Given this list of marker genes OVGP1, SNRPF, MANF, GFI1, ARHGAP29, KCNH2, GUCY2F, TRPC6, LAMB2, CRH, NR3C2, NOVA1, ARPC2, COL3A1, HOXD10, NECAB3, CEBPA-DT, HOXB3, TTYH1, HAPLN1, CHP2, PTPRJ, FOXN3, RXFP2, EMX2, HOXB9, RAB3C, TCL1A, MON1A, SCUBE3, HOXC6, LRRTM1, NREP, ACVR2A, ARHGAP33, DOCK4, MRPS18B, TGM5, HNRNPA3, AXIN2, EN1, GNAO1, SMAP2, CDIN1 (NCBI Gene Id 84529), KIF5A, HMGN2, PCSK5, ZBTB33, GPR151, MPP4, IGF1, SSPN, RARB, PAX2, BZW2, RTL9, CTBP2, RBPMS, FAM180A, LINC00173, IL1RAPL1, SLITRK5, ELAVL2, FOXP2 (forkhead box P2), FBXL19-AS1, OSBPL7 (oxysterol binding protein like 7), MED27, B3GLCT, GLRA1, BCL9L, PDZRN4, CRY1, ABLIM3 (actin binding LIM protein family member 3), CELF4, MAST2, CSF2, ZNF277, MARCKS, TINAG, SLC5A2, NPAS3 (NCBI Gene Id 64067), DMD, SIAH3, PKP4, SP6, CNTLN, FRY, UCN2, PLEC (NCBI Gene Id 5339), MYH13, ATP2A3, GRIK3, PHF3, ETV6, KCNK18, IKZF2, MEOX2, MCTP1, PI4KA, RFX4, KRTAP19-5, GDF7, ENO3, JADE1, ARHGAP8, ZBTB2, SOX1, CA10 (carbonic anhydrase 10), SOX14, NCKAP5, CPB1, MIR600HG, SMG5, PPP1R14D, MXI1, ZIC2, TSSK1B, JAKMIP2, RAB33A, TAFA1, APOBEC2, C1orf87, COL19A1, TMEM179 (transmembrane protein 179), HOXB2, BRINP3, STMN2, KIF1B, AGTR2 (NCBI Gene Id 186), SOAT2, IL3, LBX2-AS1, ERG, DLC1, ARHGEF38, SLC43A3, PPP1R2C, SUCNR1, WWC2, CPLX2, OSTC, MYOD1, ABLIM2, CALB1, MYOG, CAMK2D, SAMD11, BNC2, UBE2W, NKD1, NUDT2, ADD3, RBMXL2, NAP1L5, EYA1, MAP4K2, PPP2R2B, PWWP2B, PDZD2, PRKG2, NFIX, CALD1, RGS8, NEUROD6, RNF43, H3-3B, SMARCA2, PI15, CPNE1, EIF4E, ANGPTL3, CDH9, HOXA1, KCNA3 (NCBI Gene Id 3738), PALMD, LRP8, TBXAS1, ATP2A2, ZIC1, CSRNP1, ARF4, APRG1, SCGB3A2, TAC1, OMG, DACH1 (NCBI Gene Id 1602), FAM135B, HOXD3, SP4, MN1, ANK2 (NCBI Gene Id 4028), F9, CLC, SLC12A1, WNT4, GOLGA1, CARMIL1, SLC2A13, PRICKLE1 (prickle planar cell polarity protein 1), SPRED1, PPP1R10, HNMT, MAGI3, OTOP3, DYRK1A, SOX2, SPAG6 (sperm associated antigen 6), NXPH4, DKK4, DSG3, GPX1, SYNRG, GC, FOLR2, TENM3-AS1, MSS51, IGF2BP3, PBXIP1, SORBS1, IRX3, ABCB5, CEBPA, TAF15 (NCBI Gene Id 8148), PRPF38B, HCRTR2, S100A16, ZNF512, G6PC1, CERS6, RAB43, PNOC, SSTR1, GRK5, LUC7L, SHISA6, IL23A, FGF5, NPTX2, COLQ, PITPNC1, RBM39, MBNL2, RNF212, RASL11B, GARIN1B, C8orf17, PLCXD2, CHM, MLIP, CA4, PRKAG1, CFL2, ELMO1, DAAM1, FBXL19, PJA2, FNDC3A, DHX58, KCTD8, MITF, STARD13, HNF1A, ZCCHC24, UBE4B, AQP5, TMEM79, NOB1, RBFOX1, HOXA2, AKIRIN2, LMO4, RASGEF1B, RTKN2, WBP2NL, SAT1, EVX1, NEB, HOXC10, SMPX, SLC16A10, C12orf50, CCDC148, ANKS1B, KCTD12, ZBTB18, POU3F4, WNT6, PKD2L2, TMEM184B, VAT1, ANKMY2 (ankyrin repeat and MYND domain containing 2), GPC3, CPEB4, EHF, CSF3, TMIE (transmembrane inner ear), MOXD1, FLRT3, POLR3D, GRIA3, CTNNA3, ACKR3, TMBIM1, ZNRF1, EGR3, APP, ST7, SEMA3A, TCF7L2, SORT1, USP51, SEC14L2, GRIN2B, HOXA7, CRCT1, STAT5B, PRDM13, BHLHE22, HOXB7, NALCN, FAM91A1, POU6F2 (POU class 6 homeobox 2), CREB5, NOL4L, NANOS1, DCX, AGAP4, TJP2, CCDC171, IL21 (NCBI Gene Id 59067), ROBO3, HOXA10, PHF20L1, ORAI3, C1QTNF3, BMPR1B, GARIN4, STAT3, QKI, PRL, AFF2, ZBTB37, ADAMTS6, KCNQ4, THBS1, PTF1A, SLITRK2, MAP2K5, LINC00671, COL4A6, RPRD2, SLC13A1, TLE4, F12, DNAJB4, BEND6, DLG2, KRT77, KRTAP11-1, CCDC80, MIR9-1HG, KCNIP2 (NCBI Gene Id 30819), WWP2, NDP, MBL2, ID2, GABRB3, DCSTAMP, NSD1, CCNYL1, YIPF7, SLC38A3 (NCBI Gene Id 10991), BEND4, SYT1, PLEKHH3, E2F1, DOCK7 (NCBI Gene Id 85440), SUPT4H1, PTCHD1, TRERF1, SUMO4, HOXB4, here is a description of the gene set: Comprehensive identification of all functional elements encoded in the human genome is a fundamental need in biomedical research. Here, we present a comparative analysis of the human, mouse, rat and dog genomes to create a systematic catalogue of common regulatory motifs in promoters and 3' untranslated regions (3' UTRs). The promoter analysis yields 174 candidate motifs, including most previously known transcription-factor binding sites and 105 new motifs. The 3'-UTR analysis yields 106 motifs likely to be involved in post-transcriptional regulation. Nearly one-half are associated with microRNAs (miRNAs), leading to the discovery of many new miRNA genes and their likely target genes. Our results suggest that previous estimates of the number of human miRNA genes were low, and that miRNAs regulate at least 20% of human genes. The overall results provide a systematic view of gene regulation in the human, which will be refined as additional mammalian genomes become available. from publication Xie X, Lu J, Kulbokas EJ, Golub TR, Mootha V, Lindblad-Toh K, Lander ES, Kellis M (PMID 15735639) Genes having at least one occurrence of the highly conserved motif M97 YATTNATC in the regions spanning 4 kb centered on their transcription starting sites. The motif does not match any known transcription factor binding site. species: Homo sapiens Human Gene Set: YATTNATC_UNKNOWN